Given this list of marker genes Gabrb3, Slc1a3, Rtn4, Gba2, Dnmt3a, Calr, Bloc1s3, Mboat1, Trip11, Dtx1, Clic5, Gpr37l1, Usp21, Samd11, Ptk2, Pbx4, Gli2, Adcy1 (adenylate cyclase 1), Ptpn9, Cdk5r1, Rit2, Acsl6, Olfm1, Nme2, Rpgr, Pitx3, Prkn, Rest, Eomes, Zeb2, Stmn4, Ift56, Hipk2, Casp6, Hoxa2, Myt1l, Tlx1, Carm1, Lpar1, Dgkg, Eif4e, Stxbp1, Prex2, Kif3c, Kcnq2, Inpp5j, Mecp2, Mir133b, Or10a4, Cyb5d2, Alcam, Racgap1, Tshr, Ptk6, Ferd3l, Stk11, Gbx2, Mmd, Wls, Sdk2, Egfr, Tbx20, Nox1, Psap, Lamc3, Tubb2b, Trpc5, Rufy3, Astn2, Irx2, Phox2a, Ppp1r9a, Rab35, Foxa2, Myo7a (myosin VIIA), Actb, Mir18, Dbn1, Fgfr2, Dmrta2, Git1, Fgf13, Mir183, Twist1, Kcnq1, Sema3d, Tcf3, Zdhhc15, Dynlt1f, Sema3g, Wdr47, Lrp8, Cx3cr1, Uhmk1, Becn1, Socs2, Mcoln3, Helt, Ust, Rb1, Efhc2, Bag5, Micall1, Tunar, Lgi1, Prox1, Lonrf2, Myot, Vldlr, Jag1, Mov10, S100b, Ppp1r9b, Ccr5, Dagla, Barhl1, Chrna7, Fktn, Tox, Dbnl, Nrg1, Itga3, Ercc3, Spag6, Kcna1, Lhfpl5, Bhlhb9, Hsp90aa1, B2m, Flna, Asap1, Adcyap1, Erbb3, Bloc1s6, Inppl1, Map6, Brinp3, Ptprz1 (NCBI Gene Id 433999), Ect2, Neurod1, Cck, Rorb, Nfe2l2, Grin3a, Mir19a, Ilk, S100a9, Twf2, Ssna1, Epop, Ywhae, Lamc2, Mir92-1, Dtnb, Sez6, Opa1, Rock2, Nexn, Wnt7a, Sema4f (NCBI Gene Id 20355), Cntn6, Gsdme, Rac1, Gdf5, Ccdc39, Tle6, Axl, Serpinf1, Dvl2, Lrp6, Samd7, Tsc1, Pcdhac2, Nkx2-1, Slitrk1, Lsm1, Plxnd1, Cnp, Ptch1, B3gnt2, Ucn, Nbn, Postn, Alkal1, Ephb6 (Eph receptor B6), Fkbp1b, Fgf8, Irx3, Epha2, Cttn, Fyn, Mapkapk5, Metrn, Cxcl12, Map1s, Bax, Clmn, Slc30a1, Dnm3, Sp1, Strn, Aplp1, Ndel1, Il2, Rpl24, Ece1 (NCBI Gene Id 230857), Sema4b, Sema4c, Slitrk5, Svbp, Nedd4, Npr2, Nckipsd, Rnf6, Cpeb1, Igfals, Slitrk6 (SLIT and NTRK-like family, member 6), Nedd4l, Tctn1, Isl2, Cdc42, Aifm1, Rara (NCBI Gene Id 19401), Runx1, Cpne9, Lrp1, Smarcc2, Scn1b, Trim67, Braf, Nrn1l, P2ry2, Ptprv, Pdlim5, Myo3a, Vwc2, Prkg1, Ttc3, Slc25a46, Actr2, Fezf2, Fstl4, Sox9, Olfm3, Abi3, Actl6b, Retreg3, Mfn1, Hey2, Ier2, Ush1c, Tbce, Cpne6, Taok3 (TAO kinase 3), Sin3a, Adam10, Ndnf, Vsx2, Vcam1, Bloc1s2, Agbl4, Plppr4, Itm2c, Gpx4, Eml1, Sdk1 (sidekick cell adhesion molecule 1), Plxnc1, Agt, Tiam2, Cntnap2, Chat, Pex5, Ttc21b, Dynlt1b, Afdn, Dlg5, Bex1, Snap91, Cops2, H2-K1, Cdh2, Onecut2, Foxo6, Thap11, Efna5, Slc11a2, Acsl3, Rp1, Nkx2-5, Evx1, Jun, Hspa5, Nell2, Plaa, Sh3glb1, Ptprq, Numb, Herc2, Klf4, Filip1, Ywhah, Dhfr, Shc1, Plxnb2, Klk6, Lingo1, Nhlh2, Cdh1, Lrig2, Iqgap1, Nr2e1, Wasf1, Casz1, Mgll, Pou4f2, Gprin2, Wnt10a, Bmp5, Unc5d, Slc23a2, Ccl5, Arhgap33, Mir212, Ctnna2, Sema4a, Adgrf1, Cecr2, Srgap2, Nog, Shoc2, Alg10b, Ntf5, Inpp5f, Apbb2, Zfp365, Plxnb3 (plexin B3), Lhx3, Syt4, Setx, Micall2, Epg5, Arf4 (NCBI Gene Id 30916), Stmn2, D130043K22Rik, Map4k4, Nlgn3, Nap1l2, Vegfa, Nfib, Plxna1, Epha4, Mrtfb, Gbx1, Rab21, Tcf4, Atp9a, Lamb3, Kcnma1, Cep85, Rgma, Mob2, Adora2a, Scarf1, Atp1b2, Fat4, Dclk1, Tprn, Hoxd9 (homeobox D9), Hap1, Lhx1os, Tead3, Neurog3, Tnfrsf21, Tsc22d4, Smo, Ager, Mir200c, Neurl1a, Nlgn1, Mettl3, Eya1, Ntrk2, Gpc2, Fkbp8, Nme1, Hhip, Creb1, Aspm, Sox8, Hoxd10, Ngfr, Ss18l1, Otp, Bsg, Rdh13, Kifbp, Camsap3, Gdf2, Camk2b, Pcdh15, Flrt3, Ezh2 (enhancer of zeste 2 polycomb repressive complex 2 subunit), Ndrg4 (NCBI Gene Id 97495), Slc6a4, Wnt8b, Ngf, Hand2, Gla, Vasp, Ptprs, Vmn2r82 (NCBI Gene Id 635124), Disp3, Cabp4, Lama2, Prex1, Insm2, Sufu, Minar2, Unc5a, Ptprd, Rap1gap, Psen1, Alms1, Ncam1, Neurod2, Ankrd27, Vrk1, Cdc27, Rnd2, Zfyve27, Pitpna, Zdhhc16, Diaph2, B4galt5, Ugcg, Pias2, Itga1, Gabrb1, Tyro3, Mtmr2, Arl3, Smim45, Bcl6, Zhx2, Atp8b1, Tmem132e, Rap1gap2, Mir9-1, Crppa, Samd14, Psd, Mmp2, Ikzf1, Nexmif, Btg2, Nectin1, Ryk, Tgm3, Crtc1, Myo5b (myosin VB), Ptpn1, Notch1, Gdi1, Rtn4rl2, AU040320, Trak1, Pdgfb, Med1, Fes (feline sarcoma oncogene), Ctnna1, Vxn, Spart, Cdkl5, Sox12, Neo1, Ppp3ca, Olig3, Itgb1, Nfasc, Heyl, Or8a1b, Hif1a, Phox2b, Gigyf2, Farp2, Smn1, Dpysl3, Dync1i2, Prdm13, Kif5b, Casp3, Kif20b, Pum2, Ppp2r3a, Rtn3, Vmn2r65, Cntn4, Cdk5r2, Vcl, Adra2b, Neurod6, P3h1, Neurog2, Pcsk9, Celsr2, Epor, Ntng1, Sema3e, Fzd4, Grin1, Ube3a, Kidins220, Gas1, Pld2, Pla2g3, Sdccag8, Bhlha15, Ptger3, Erbb2, Adm, Rnf7, Cntf, Borcs7, Ush2a, Dguok, Csmd3 (CUB and Sushi multiple domains 3), Evl, Hecw2, Ptk7, Skil, Kcnq3, Dynlt1a, Nfix, Auts2, Fbxo41, Nsmf, Mfrp, Sirt1, Bmp7, Cdkl3, Daglb, Lzts3, Cep85l, Jag2, Sox1, Dscam, Grip2, Scyl2 (NCBI Gene Id 52687), Fgfr1, Chodl, Tspo, Fzd3, Bhlhe22, Nrdc, Syt3, Il1r1, Rnf220 (NCBI Gene Id 70613), Lifr, Hoxd3, Nptn, Gli3, Hes1, Prdm8, Megf9, Cdon, Zdhhc17, Slit1, Alkbh1, Jade2, Smarca1, Mks1, Snx3, Efnb2, Irx1, Tgfbr1, Spag6l, Septin4, Stk24, Rab8a, Cd3e, Nck1, Apbb1, Tor1a, Cobl, Adcy10, Acsl4 (NCBI Gene Id 50790), Pals1, Irx4, Mark1, Wdr5, Hmg20a, Grxcr1, Wnt9b, Sec24b, Bbs4, Macf1, Prmt1, Usp9x, Prkci, Adgrl3, Mir124a-1, Dlg2, Ttc8, Mcf2, Rspo2, Nr2e3, Unc5b, Scn11a, Lyn, Camsap2, Kcnb1, Pls1, Anapc2, Cxcr4, Negr1, Vangl2, Mycbp2, Tfap4, Slitrk2, Ep300, Scrt1, Plxna3, Sgk1, Gpr37, Gh, Fxn, Foxd1, Pitx2, Lin28a, Zfhx3, Cib1, Atn1, Rom1 (NCBI Gene Id 19881), Sema3a, Zmynd8, Rtn4rl1, Hoxc10, Mark2, Samd4b, Pdzd7, Tgif2, C3, Ppp2r5b, Dlx5, Sema6d, Ptpn11, Sema5b, Pbx1, Syt2, Wnt2b, Rims1, Acp4, Eif4enif1, Cul4b, Thy1, Nefl, Cdc20, Arhgef28, Gdf11, Lhx8, Cep290, Omg, Gabra5, Nlgn2, Brinp2, Ist1, Prkd1, Trpm1, Rasgrf1, Ptpru, Scyl3, Kif26a, Id2, Fev (FEV transcription factor, ETS family member, NCBI Gene Id 260298), Srrm4, Cask (NCBI Gene Id 236691), Tmem106b, Foxb1, Tecta, Fut9, Nefh, Prdm12 (PR domain containing 12), Prkca, Palm, Impact, Nkx6-2, Bicdl1, Adam17, Noto, Chrnb2, Ahi1, Camk2a, Phactr1, Obsl1, Nphp1, Etv4, Fgf20, Neu1, Arhgef25, Timp2, Avil, Acte1, Vwc2l, Diaph1, B4gat1, Insm1, Atf4, Spg21, Tfap2c, Atf1, Syn1, Il15ra, Aldh1a2, Tenm4, Gngt1, Dnm1l, Trpv4, Cacng7, Arc, Anks1, Pex2, Btbd3, Tbx1, Ntn4, Rgs2, Bmp4, Hoxd1, Lmo4, Stau2, Shtn1, Epha8, Slitrk3, Trpc6, Nrp1, Septin14, Inhba, Lhx2, Cdh23, Lamc1, Atg16l1, Ptprf, Camk2g, Alkal2, Pcm1, Dlx1, Map3k13, Wdr36, Eif2ak4, Eif4g1, Ncam2, Enc1, Sox5, Lrrc7, Stat3, Crb2, Cntnap4, Gdf6, Ogdh, Lrp12, Atxn2, Pak6, Pex7, Cdk5, Rbfox2, Sox11, Sall3, Olig1, Lama5, Fzd1, Efnb1, Wnt7b, Trp73, Stmn3, Ikbkb, Grid2, Nipbl, Vmn2r120, Nkx2-9, Ighmbp2, Ifng, Dennd5a, Cul7, Pqbp1, Nrep (NCBI Gene Id 27528), Plp1, Cux1, Dhx36, Ppp1cc, Epha10, Tlx2, Ubb, Actr3, Cpne1, Bmp6, Ptprt, Rab3a, Pax7, Reln, C1ql1, Epo, Tsc2, Dll1, Agtpbp1, Mfn2, Sox3, Alk, Spag9, Chrdl1, Matn2, Naglu, Clrn2, Cngb1 (cyclic nucleotide gated channel beta 1), Trim32, Mir17, Myo9a, Ptn, Pjvk, Irx6, Vax1, Ephb3, Mypn, Adarb1, Hecw1, Parp6, Ripor2, Edn2, Bloc1s5, Grip1, Rasal1, Trappc4, Mir429, Skor2, Ptprh, Adnp, Flot1, Fig4, Kndc1, Pafah1b1, Cend1, Dct, Sema6c, Efna2 (NCBI Gene Id 13637), Pcnt, Duoxa1, Mycl, Uba6, Gdpd5, Mycn, Ercc2 (excision repair cross-complementing rodent repair deficiency, complementation group 2), Hs6st1, Ncdn, Hcn1, Hoxc8, Wnt3a, Kdr, Dip2b, Gprin1, Adra2c, Arid1b, Ccdc88a, Boc, Taok2, Sh3rf1, Uncx, Sult4a1, Whrn, Otog, Itpr1, Lhx1, Fam168b, Arf1, Tmem67, Ppp1r12c, Dbx1, Hdac1, Arhgap32, Dnmt3b (DNA methyltransferase 3B), Arsb, Cebpb, Ehd1, Lhx5, Srcin1, Large1, Thbs4, Ntng2, Ift27, Met, Cln8, Nrxn1, Kifc2, Apc, Apoe, Lnx2, Lypd6, Cthrc1, Tspan2 (tetraspanin 2), Bin1, Mdm2, Ptbp1, Xk, Mib1, Fos, Clu, Dcx, Myoc, Epb41l3, Bmpr2, Cacna1f, Twf1, Kel, Cacna1a, Ift140, Tomt, Pigt, Trp53, Ablim1, Ddr2, Neurog1, Khdc3, Tbx6, Upf3b, Ppp1r12b, Runx1t1, Artn, Bmpr1b, Mapt, Vps54, Phgdh, Frmd7, Acap3 (ArfGAP with coiled-coil, ankyrin repeat and PH domains 3), Sox15 (NCBI Gene Id 20670), En1, Reg1, Gnrh1, Ephb2, Abt1, Ush1g, Bloc1s1, Tubb3, Dvl3, Cfl1, Diaph3, Trappc9, Apoa4, Nepro, Cyth2, Mpdz, Prrx1, Spg11, D16Ertd472e, H2-D1, Sod2, Fbxo31, Pbx3, Garem2, Eif4g2, Sh3gl3, Mylip, Wnt4, Prl2c2, Dvl1, Clrn1, Limk1, Akna, Ache, Hdgfl3, Th, Mbp, Astn1, Wnt8a, Camsap1, Cdkn1c, Caprin1, Col3a1, Pak2, Ngef, Snx1, Fas, Arhgef2, Tgfb1, Tsku, Lama3, Kirrel3, Tgfb2, Pou3f4, Abitram, Ttl, Grxcr2, Gfra3, Cdh4, Triobp, Lef1, Nr2f6, Ifrd1, Dnaaf4, Minar1, Ddx6, Tbr1, Cc2d1a, S1pr1, Lama1, Mapk6, Efemp1, Afg3l2, Bmp2, Gnat2, Lgi4, Tenm2, Vmn2r81, Sptbn4, Rgs6, Akap5, Katna1, Dip2a, Kat2b, Unk, Vmn2r83, Mir141, Bcan, Agrn, Npy, Serpini1, Ltk, Abi3bp, Pin1, Ncs1, Cdh11, Fbxo38, Sod1, Ttc36, Bccip, Prom1, Pax6, Mul1, Rtn1, Drd1, Grn, Fkrp, Golga2, Slc4a7, Zfp296, Egr2, Fam151b, Ascl2, Rabl2, Vax2 (NCBI Gene Id 24113), Efna3, Nyap2, Ghrl, Nf1, Nanos1, Gpm6a, Cspg5, Syt1, Raph1, Caprin2, Snph, Golga4, Zic3, S1pr5, Cd44, Kdm4a, Pak4, Rap2a, Gm2990, Foxa1, Emb, Mir200b, Mapk8ip2, Lhx9, Slc9a6, Lhx6, Bhlhe23 (NCBI Gene Id 319514), Lrp2, Ptpro, Frs2, Flrt2, Flrt1, Mtr, Nherf1, Plppr5, Klf9, Tbcd, Dab2, Gsx2, Marcks, Pde6c (NCBI Gene Id 18581), Dubr, Dmrt3, Stmn1, Map2k1, Llph, Etv1, Slc44a4, Ntn3, Ephb1, Qki (NCBI Gene Id 66145), Foxn4 (forkhead box N4), Dicer1, Scyl1, Celsr1, Tnn, Mt3 (NCBI Gene Id 17751), Dst, Zfp521, Zpr1, Ret, Kank1, Kctd11, Pou4f1, Nefm, Itsn1, Drd2, Il6, Mef2a, Efnb3, Hexa, Elp6, Kdm1a, Tbc1d23, Rapgef4 (NCBI Gene Id 71744), Iqsec1, Zzef1, Kdm4c, Wnt5a, Mir132, Cip2a, Hmg20b, Kif1a, Itga6, Apoa1, Dmd, Ncoa1, Cyfip2, Cbfa2t2, Six3os1, Map1a, Jak2, Vapa, Tmc1, Ntn1, Rab17, Slc4a10, Nkx2-2, Ptpn5, Tdp2, Wasf2, Ednrb, Xylt1, Ank3, Cpeb3, Prickle2, Gata2, Dok5, Epha6 (NCBI Gene Id 13840), Tuba1a, Fbxw8, Scrib, Strap, Ctnnd2, Nr2f2, Kif3a, Ankrd24, Igsf10, Mfsd2a, Gak, Plxna4 (NCBI Gene Id 330281), Cd24a, Sdc4, Myo6, Igf2bp1, Vhl, Bcl2, Zfp536, Sema5a, Htt, Ube4b, Nrcam, Stx3, Myo3b (NCBI Gene Id 635238), Amigo1, Atp2b2, Ntn5 (NCBI Gene Id 243967), Celsr3, Igf1r, Htr7, Prph2, Kifap3, Ptprk (protein tyrosine phosphatase receptor type K), Shank1, Nck2, Hgf, Ddit4, Cflar, Camk1d, Sox2, Robo1, Mir200a, Klhl1, Ptk2b, Efna1, Rfx6, Rims2, Farp1, Ntf3, Atf5, Dixdc1 (DIX domain containing 1), Ntrk1, Itga4, Folr1, Tubb2a, Nckap1l, Zbtb18, Lzts1, Arx, Styxl1, Dlx3, Mag, Ctdsp1, Drgx, Bend6, Erbb4, Wnt2, Megf8, Dpysl5, Neu4, Areg, Prtg, Fscn2, Cux2, Sox21, Cyfip1, Rap1a, Nfatc4, Cpne5, A830082K12Rik, Xbp1, Efhd1 (NCBI Gene Id 98363), Zic2, Esrp1, Bbs1, Stk25, Nrp2, Chl1, Rab10, Dab1, Brsk2, Pax2, Adgrv1, Ulk4, Zc4h2, B4galt6, Nr2f1, Ppp2r5d, Sf3a2, Nin, Ext1, Top2b, Ulk1, Nfe2l1, Vps13a, Nr3c1, Gas7, Hes5, Zfp212, Lif, Sema4d, Gsk3a, Fmr1, Pak1, Pax3, Srf, Zmiz1, Itsn2, Klk8, Epha3, Cspg4, Atl1, Rtn2, Hdac6, Tubgcp2, Mir96, Thrb, Ythdf1, Foxo3, Crb1, Tnr, Cers2, Map2k2, Mrtfa, Mir9-2, Lhx4 (LIM homeobox protein 4), Tnxb, Wasl, Nif3l1, Igsf9, Klf7, Fshr, Cd2ap, Prmt3, Satb2, Dag1, Hspb1, Snap25, Kalrn, Map1b, Crkl, Csnk1d, Ark2c, Wnt16, Katnb1, Ldb1, Camk1, Otx2, Taok1, Mir20a, Lamb1, Pmp22, Picalm, Robo3, Galr2, Rac3, Gfra1, Draxin, Lbx1, Llgl1, Chrd, Shox2, Lamb2, Abi2, Enpp1, Mmd2, Secisbp2, Nckap1, Bcl11a, Six3, Plxnb1, Gm28836, Mir124a-2, Poc5, Map2, Corin, Sclt1, Kif21a, Crp, Adgrg1, Mtpn, Nrg3, Tnik, Syt17, Runx3, Ap5z1, Pacsin1, Gabrb2 (gamma-aminobutyric acid type A receptor subunit beta 2), Dock10, Nr4a3, Rpl4, Sema3f, Ndp, Gprc5b, Ngb, Tbc1d24, Tfap2a, Mfsd8, Trio, Id1, Atxn10, Foxp2, Apod, Tenm3, Hnrnpk, Emx2, Ntm, Dzank1 (double zinc ribbon and ankyrin repeat domains 1), Nova2, Fezf1, St8sia2, Sarm1, Fmc1, Actbl2, Islr2, Slc38a8, Fryl, Clasp2, Csf1r (colony stimulating factor 1 receptor), Cul5, Rho, Zswim6, Tafa1, Gabrr2, Ap2a1, Tanc2, Crtac1, Brsk1, Pomgnt2, Tlx3, Unc5c, Crebbp, Aplp2, Rnf112, Plk2, Tmem30a (transmembrane protein 30A), Tulp1, Spr, Clip1, Hes3, Spock1, Onecut1, Wnt11, Ednra, Mapk9, Lrrk2, Neurod4, Ccnd1, Wnt10b, Ndufs4, Plk5 (NCBI Gene Id 216166), Cntnap1, Mdga2 (MAM domain containing glycosylphosphatidylinositol anchor 2), Rbpj, Olig2 (NCBI Gene Id 50913), Six1, Ercc6, Esr2, Brinp1, Ddr1, Abcb1b, Ptf1a, Gdf7, Dact1, Sox4, Ppia, Prickle1, Lep, Vegfc, Nav1, Ift172, Isl1, Abl1, Mdk, Ppp1r12a, Adcy6, Dync2h1, Dlg4, Cdhr1, Scrt2, Tpbg, Rpgrip1, Smarcd3, Bbs10, Xrn2, Atat1, Xlr3b, Ndn, Als2, Akt1, Sdc2, Tcf12, Rab11a (RAB11A, member RAS oncogene family), Shank3, Cntn3, Numbl, Wnt5b, Slc39a12 (NCBI Gene Id 99291), Ugt8a, Emx1 (empty spiracles homeobox 1), Lmx1a, Mnx1, Mir9-3, Cnr1, Fkbp4, Vax2os, Fbxo45, Spast, Serpine2, Dlx2, Abl2, Mturn, Barhl2, Ywhaz, Tiam1, Arf6, Ugdh, Six4, Scarb2, Zfp804a, Tenm1 (NCBI Gene Id 630184), Gas6, Pcare, Gsk3b, C9orf72, Eif2b2, Trpv2, Sema3b, Sfrp1, Edn3, Atcay, Spire1, Arhgap44, Fry, Faim2, Atg7, Robo2 (NCBI Gene Id 72126), Crmp1 (collapsin response mediator protein 1), Baiap2, Hipk1 (homeodomain interacting protein kinase 1), Lpar3 (NCBI Gene Id 65086), Htra2, Rtn4r, Bahcc1, Stxbp5, Reno1, Pip5k1c, Dclk2, Mosmo, Dab2ip, Mdga1, Herc1, L1cam, Uchl1, Gata3, Ntrk3, Nfia, Ptprm, Nphp4, Pax5, Irx5, Gap43, Mettl14, Atoh1, Thoc2l, Nrn1, Wnt9a, Arhgap4, Gldn, Rapgef2, Disc1 (disrupted in schizophrenia 1), Dcdc2a, Rnd1, Prkcsh, Cdnf, Cd38 (NCBI Gene Id 12494), Runx2, Wee1, Sall1, Cfh, Smurf1, Aurka, Pak3, Nek3, Dll4, Crk, Crabp2, Ift88, Mef2c, Grk1, Meis1, Sema6a, Pla2g10 (NCBI Gene Id 26969), Kcnip2 (Kv channel-interacting protein 2), Usp33, Fcgr2b, Chn1, Sfrp2, Arhgap35, Actg1, Ube2v2, Bag1, Rhoa, Il1b, Nkx6-1, Map4, Vegfd, Sema7a, Gpm6b, Rtn4ip1, Epha5, Arfgef1, Ranbp1, Ywhag (tyrosine 3-monooxygenase/tryptophan 5-monooxygenase activation protein, gamma polypeptide), Dynlt1c, Nptxr, Fat3 (FAT atypical cadherin 3), Ctnnb1, Ttll1, Tnfrsf12a (NCBI Gene Id 98086), Wnt6, Efna4 (ephrin A4), Mir376a, Sipa1l1, Zfhx2, Tulp3, Slit3 (slit guidance ligand 3), Fuom (NCBI Gene Id 69064), Sema6b, Lrp4, Kif5a, Rere, Sox10, Itpka, Slc12a5, Il1rapl1 (interleukin 1 receptor accessory protein-like 1), Eef2k, Elmod3, Nrl, Gprin3, Ppfia2 (protein tyrosine phosphatase, receptor type, f polypeptide (PTPRF), interacting protein (liprin), alpha 2), Kif13b, Prag1, Thoc2, Vsx1, Rrn3, Bcl7a, Bnip2, Zeb1, Dock7, Gorasp1, Miat, Dbndd2, Napa, Tug1, Lrrc4c, Fbxo7, Elp3, Id3, Gnaq, Rtca, Cbln1, Adgrb3, Foxp1, Lgals1, Nrtn, Paqr3, Hdac2, Uqcrq (NCBI Gene Id 98240), Ascl1, Cnga3, Sema4g (sema domain, immunoglobulin domain (Ig), transmembrane domain (TM) and short cytoplasmic domain, (semaphorin) 4G), Ehmt2, Shh, Hoxa1, Ctf1, En2, Lmtk2, Chd5, Rapgef1, App, Rp1l1, Col25a1, Grcc10 (NCBI Gene Id 80671), Sh3gl2, Atp8a2, Mgarp, Vash2, Cav1 (caveolin 1, caveolae protein), Mir124a-3, Creb3l2, Hprt1, Septin7, Lst1, Cntn2, Gsx1, Lmx1b, Stx1b, Cdk5rap2 (CDK5 regulatory subunit associated protein 2), Vmn2r1, Pbx2, Trak2, Id4, Gfi1, Ankrd1, Cx3cl1, Elavl4, Cfap418, C1qa, Bdnf, Wdr62, Magi2, Rpgrip1l, Zfp335, Wnt1, Atoh7, Tmem108, Septin2, Trim46, Nptx1, Nrbp2, Slitrk4, Ptprj, Prkcz, Dtnbp1, Washc5, Hey1, Tgif1, Bmpr1a, Dleu2, Vmn2r26, Ihh, Ulk2, Foxg1, Sphk1, Szt2, Chrna3, Mink1, Rnf157, Nyap1, Kdm2a, Syngap1, Gba1, Wdpcp, Strc, Ptprg, Dscaml1, Bche, Ift20, Epha7, Tal1, Pten, Fzd9, Smad4, Sox14, Ccr4, Tnc, Myo16, Kif5c, Tet1 (NCBI Gene Id 70318), Vim, Mapk8ip3, Dcc, Mapk8, Nr4a2, Fzd2, Cxcl5, Amigo3, Etv5, Mir182, Ctf2, Rock1 (NCBI Gene Id 68785), Ostn, Grm7, Mtor (NCBI Gene Id 80612), Dkk1, Sema3c, Myh10, Pex13, Gdnf, Nkx6-3, Pcp4, Bcl11b, Fgf2, Ddx56, Mir19b-1, Atp7a, Dpysl2, Dnm2, Kremen1, Pbrm1, Cntn5, Zfp609, Bloc1s4, Gfap, Dio3, Unc13a, Rora, Pou3f2, Nbl1, Gpr173, Rab13, Snapin, Slit2, Ophn1, Adamts1, Fez1, Rab29, Enah, Clstn3, Cdk16, Fgfr3, Lgr4, Wnt3, Otogl, Edn1, Gja1, Cntn1, Fn1, Notch3, Gnat1, Cckar, Pou4f3, Abi1, Prdm1, Nde1 (NCBI Gene Id 67203), Cit, here is a description of the gene set: The process in which nerve cells are generated. This includes the production of neuroblasts and their differentiation into neurons. Mouse Gene Set: GOBP_GENERATION_OF_NEURONS species: Mus musculus